The following is a description of a gene set: Mouse Gene Set: GOMF_NADPLUS_PROTEIN_ASPARTATE_ADP_RIBOSYLTRANSFERASE_ACTIVITY studied in species Mus musculus Catalysis of the reaction: L-aspartyl- + NAD+ = 4-O-(ADP-D-ribosyl)-L-aspartyl- + nicotinamide., and this is the list of marker genes: Parp11, Parp6, Parp1, Tiparp (NCBI Gene Id 99929), Parp2, Tnks2, Parp12, Parp16, Tnks, Parp10, Parp4, Parp3